The following is a description of a gene set: Genes from the magenta module which are dn-regulated in HAEC cells (primary aortic endothelium) after exposure to the oxidized 1-palmitoyl-2-arachidonyl-sn-3-glycerophosphorylcholine (oxPAPC). species: Homo sapiens Human Gene Set: GARGALOVIC_RESPONSE_TO_OXIDIZED_PHOSPHOLIPIDS_MAGENTA_DN from publication Gargalovic PS, Imura M, Zhang B, Gharavi NM, Clark MJ, Pagnon J, Yang WP, He A, Truong A, Patel S, Nelson SF, Horvath S, Berliner JA, Kirchgessner TG, Lusis AJ (PMID 16912112) Oxidized phospholipids are thought to promote atherogenesis by stimulating endothelial cells (ECs) to produce inflammatory cytokines, such as IL-8. In studies with mouse models, we previously demonstrated that genetic variation in inflammatory responses of endothelial cells to oxidized lipids contributes importantly to atherosclerosis susceptibility. We now show that similar variations occur in cultured aortic ECs derived from multiple heart transplant donors. These variations were stably maintained between passages and, thus, reflect either genetic or epigenetic regulatory differences. Expression array analysis of aortic EC cultures derived from 12 individuals revealed that >genes were regulated by oxidized phospholipids. We have used the observed variations in the sampled population to construct a gene coexpression network comprised of 15 modules of highly connected genes. We show that several identified modules are significantly enriched in genes for known pathways and confirm a module enriched for unfolded protein response (UPR) genes using siRNA and the UPR inducer tunicamycin. On the basis of the constructed network, we predicted that a gene of unknown function (MGC4504) present in the UPR module is a target for UPR transcriptional activator ATF4. Our data also indicate that IL-8 is present in the UPR module and is regulated, in part, by the UPR. We validate these by using siRNA. In conclusion, we show that interindividual variability can be used to group genes into pathways and predict gene-gene regulatory relationships, thus identifying targets potentially involved in susceptibility to common diseases such as atherosclerosis., and this is the list of marker genes: ETAA1, IMP3, DIDO1, IRAK1BP1, RSBN1L, KBTBD6 (NCBI Gene Id 89890), RANBP6 (RAN binding protein 6), AGGF1, GPAM, MIDEAS, DBR1, RTL6